Given this list of marker genes LCAT, PAFAH2, PLA2G10, PLA2G6, ASPG, PLA2G7, PAFAH1B3, PAFAH1B2, here is a description of the gene set: studied in species Homo sapiens Human Gene Set: GOMF_1_ALKYL_2_ACETYLGLYCEROPHOSPHOCHOLINE_ESTERASE_ACTIVITY Catalysis of the reaction: a 1-O-alkyl-2-acetyl-sn-glycero-3-phosphocholine + H2O = 1-O-alkyl-sn-glycero-3-phosphocholine + acetate + H+.